The following is a description of a gene set: part of: Cellular response to heat stress Acquisition of DNA binding activity by HSF1 is necessary but insufficient for transcriptional activation (Cotto JJ et al. 1996; Trinklein ND et al. 2004). In addition to having a sequence-specific DNA binding domain, HSF1 contains a C-terminal region which is involved in activating the transcription of the target genes (Green M et al. 1995). However, the transactivating ability of the transactivation domain itself is not stress sensitive. Rather, it's controled by a regulatory domain of HSF1 (amino acids 221-310), which represses the transactivating ability under normal physiological conditions (Green M et al. 1995; Zuo J et al. 1995; Newton EM et al. 1996). The HSF1 transactivation domain can be divided into two distinct regions, activation domain 1 (AD1) and activation domain 2 (AD2) (Brown SA et al. 1998). AD1 and AD2 each contain residues that are important for both transcriptional initiation and elongation. Mutations in acidic residues in both AD1 and AD2 preferentially affect the ability of HSF1 to stimulate transcriptional initiation, while mutations in phenylalanine residues preferentially affect stimulation of elongation (Brown SA et al. 1998). <p>Activation of the DNA-bound but transcriptionally incompetent HSF1 is thought to occur upon stress induced HSF1 phosphorylation at several serine residues (Ding XZ et al. 1997; Holmberg CI et al. 2001; Guettouche T et al. 2005). In cells exposed to heat, acquisition of HSE DNA-binding activity was observed to precede phosphorylation of HSF1 (Cotto JJ et al. 1996; Kline MP & Morimoto RI 1997). While there is a sufficient evidence to suggest that phosphorylation of HSF1 is essential to modulate HSF1 transactiviting capacity, mechanisms behind stress stimuli and kinases/phosphatases involved have not been clearly established. Reactome Pathway: HSF1-dependent transactivation studied in species Homo sapiens, and this is the list of marker genes: TNFRSF21, DNAJB1, HSPA1A, FKBP4, HSF1, CAMK2G, MLST8, COL4A6, HSBP2, GML, SERPINH1, HSP90AB1, HSPB2, DNAJB6, MRPL18, CAMK2B, EP300, CAMK2A, CRYBA4, HSPA1B (NCBI Gene Id 3304), DEDD2, HSPB8, HSPA2, CRYAB, RPTOR, PTGES3, HSP90AA1, RLN1, HSPA1L, MTOR, UBB, HSBP1, CREBBP, HSPA8, HSPB1, HSPA6, HSPH1, AKT1S1, CAMK2D